The following is a description of a gene set: Mouse Gene Set: GOBP_REGULATION_PROTEIN_CATABOLIC_PROCESS_AT_POSTSYNAPSE Any process that modulates the frequency, rate or extent of the chemical reactions and pathways resulting in the breakdown of a protein at the postsynapse. studied in species Mus musculus, and this is the list of marker genes: Klhl17, Ube2n, Pin1, Nedd4l, Cul3, Cblb, Egln1, Trim3, Nedd4, Vhl